Given this list of marker genes CTNND1, MAP3K1 (NCBI Gene Id 4214), POM121L2, IFFO1, AQR, SUOX, TTF1, CKAP2, NUP133, MMD, TM9SF4, DYNLL1, SLC25A14 (NCBI Gene Id 9016), SCAPER, NTHL1, GABRA3, ASB1, CLSTN1, ZMIZ1, ITGB6, WSCD1, ZNF821, ZW10, POT1, HMX1, GJB1, TMEM70, NVL, SEC61A1 (SEC61 translocon subunit alpha 1), NMRK2, DCUN1D2, RNF103, GNPDA1, EPS8, KANSL2, SEC14L5, PREP, SLC25A38, OR7E36P, ENTR1, KAT7, HIC2, LDLRAD4, OBI1, NINJ2, BCLAF1, ADGRE3, TIMM8A, ADNP, UQCRB, MGA, GIT2, KMT5B, ASH1L, TBC1D9B, R3HDM1, ILKAP, PCMTD2, PHF7, ARHGEF18, IVD, AP5S1, EEF1B2, ZSCAN16, CCDC82, WDR33, PRMT5, CBFB, TPGS2, IQCB1, ZC4H2, PDE4A, TMX4, POLR1C, SLC35A1, LBHD1 (LBH domain containing 1), PPFIA4, TRPS1, OXSM, BLMH, ZNF74, ROR1, CCDC91, R3HCC1, AP3M2, PRKAR2A, CMC4, MPHOSPH8, THBS2, CSNK1G2 (NCBI Gene Id 1455), AAGAB, UTP14C, PPP1CC, AKR7A2, PBLD, NUP88, CENPE, RMND5B, ZNF93, MED9, AURKB, KRT37, GATAD2A, VCL, REPS1, KRT76, GAPDHS, ACTMAP, ZDHHC17 (zinc finger DHHC-type palmitoyltransferase 17), E2F2, MRPS27, PEX2, RIOX2, IRS1, THAP12, DCAF10, RANGRF, PI15, DOCK6, FAM168A, PPP1R8, ARHGAP15, BMAL1, CDC14B, AVL9, PLCXD1, FRAT2, ARHGEF40, TOP2B, KIF2C, HDAC6, SYNJ2BP, COG4, PCSK7, RPUSD2, RFC3, PPME1, POLD3, NCK1, PDSS2, LARP1, DDX46, DPP8, GFOD1, HSPD1, SLC6A1, AFG3L2, SS18L1, LEPROTL1, THAP7, ERF, ZKSCAN5, MEGF9, PGRMC2, CLPX, INPP5B, RPS26, DPH5, GPR65, KCNIP1, REXO4, RBM26, BRD8, RRH, CAD, CDC23, MPI, ANKRD34C, MRPL20, PHC2, CLUAP1, METTL18, THOC2, ZNF83, ICMT, LAMTOR2, RUFY1, NOP53, DPH2, ADGRA3, LAS1L, HMMR, EPM2A, NUP37, SV2A, UBR7, MAF, ZNF281, BRD4, ZNF473, TMA7, ARHGEF9, LRRC31, DUSP12, CCDC90B, C2CD3, SPI1, RUBCNL, ORC5 (origin recognition complex subunit 5), GABARAPL3, here is a description of the gene set: from publication Jeffrey KL, Brummer T, Rolph MS, Liu SM, Callejas NA, Grumont RJ, Gillieron C, Mackay F, Grey S, Camps M, Rommel C, Gerondakis SD, Mackay CR (PMID 16474395) Human Gene Set: GSE3982_CTRL_VS_LPS_4H_MAC_UP In the present study we used Affymetrix oligonucleotide microarrays to produce gene transcription profiles for the major leukocyte types in humans. This comprehensive dataset enabled us to not only establish which genes were expressed in each leukocyte type, but also which genes were expressed in each subset after activation. The used of a comprehensive dataset of gene profiles from all the major human leukocyte subsets enabled a novel and powerful means for identification of genes associated with single leukocyte subsets, or different immune paradigms. species: Homo sapiens Genes up-regulated in comparison of untreated macrophages versus macrophages treated with LPS (TLR4 agonist) at 4 h.